Given this list of marker genes TOMM20L, SSB, TOMM20, NOL6, YBX1, XPOT (NCBI Gene Id 11260), here is a description of the gene set: Human Gene Set: GOBP_TRNA_TRANSPORT species: Homo sapiens The directed movement of tRNA, transfer ribonucleic acid, into, out of or within a cell, or between cells, by means of some agent such as a transporter or pore.